The following is a description of a gene set: Human Gene Set: GOBP_TRANSFORMING_GROWTH_FACTOR_BETA1_PRODUCTION The appearance of transforming growth factor-beta1 due to biosynthesis or secretion following a cellular stimulus, resulting in an increase in its intracellular or extracellular levels. studied in species Homo sapiens, and this is the list of marker genes: THBS1, LAPTM4B, TYROBP, CD2AP, FOXP3, COL3A1, CX3CL1, TSKU, LUM, FURIN, SERPINB7, GATA6, ATP6AP2